Given this list of marker genes Atp23, Mipep, Immp2l, Immp1l, Pmpcb, Yme1l1, Spg7 (NCBI Gene Id 57358), Afg3l1, Sirt4, Pmpca, Afg3l2, Oma1, Stoml2, here is a description of the gene set: studied in species Mus musculus Mouse Gene Set: GOBP_MITOCHONDRIAL_PROTEIN_PROCESSING The peptide cleavage of mitochondrial proteins, including cleavage contributing to their import.